Given this list of marker genes TDRD1, PCDHB7, USP18, HOXD4, TAF7L, KCNK9, CA10, HBZ, LHX9, NPY5R, OTOP3, ADGRL3, NPAS4 (NCBI Gene Id 266743), HOXB8, ALOX15, TFAP2D, HOXD10, CACNG2, OTP, TMEM174, TMEM59L, TBX5, HTR2C, HOXA3, HPSE2, HOXB5, ASIC2, RPH3A, VSNL1, TBX4 (NCBI Gene Id 9496), PHOX2B, PCDHA11, HOXA11, NR2E1, PCDHA4, ZMYND10, PYY, NALF1, CRLF1, FOXL1, PRDM13, CACNA1G (NCBI Gene Id 8913), HOXC10, ELOVL3, PCDHA10, EVX2, KCNS1, UNCX (UNC homeobox), WNT1, FGF12, SORCS3, HOXB6, HOXB3, PRDM8, HOXC6, ZNF536 (zinc finger protein 536), GRM8, PCDHB16, EREG, CALB1, HOXB1, MYCBP2, WNT10A, HOXA2, PAPPA, TFAP2B, USH1G, OSR1, NRN1, INSRR, NFIX, PCDHA13, HOXC9, KCNIP1 (potassium voltage-gated channel interacting protein 1), SLC6A4, LRRK2, PRRT1 (NCBI Gene Id 80863), SIX3, HOXB7, GFI1, DUOX2, DBX1, IGF2, LBX1, ARX, NTM, DUOXA2, ACTL6B, PCDHA2, NR2F2, CACNA1E, HBQ1, HOXC8, MPPED1, HOXB2, TEX12 (testis expressed 12), IL10RA, CDH11, AVP, PCDH11X, SLITRK3, ACHE, SLC25A31, here is a description of the gene set: from publication Mikkelsen TS, Hanna J, Zhang X, Ku M, Wernig M, Schorderet P, Bernstein BE, Jaenisch R, Lander ES, Meissner A (PMID 18509334) species: Mus musculus Genes with high-CpG-density promoters (HCP) bearing the tri-methylation mark at H3K27 (H3K27me3) in MCV8.1 (induced pluripotent cells, iPS). Human Gene Set: MIKKELSEN_IPS_WITH_HCP_H3K27ME3 Somatic cells can be reprogrammed to a pluripotent state through the ectopic expression of defined transcription factors. Understanding the mechanism and kinetics of this transformation may shed light on the nature of developmental potency and suggest strategies with improved efficiency or safety. Here we report an integrative genomic analysis of reprogramming of mouse fibroblasts and B lymphocytes. Lineage-committed cells show a complex response to the ectopic expression involving induction of genes downstream of individual reprogramming factors. Fully reprogrammed cells show gene expression and epigenetic states that are highly similar to embryonic stem cells. In contrast, stable partially reprogrammed cell lines show reactivation of a distinctive subset of stem-cell-related genes, incomplete repression of lineage-specifying transcription factors, and DNA hypermethylation at pluripotency-related loci. These observations suggest that some cells may become trapped in partially reprogrammed states owing to incomplete repression of transcription factors, and that DNA de-methylation is an inefficient step in the transition to pluripotency. We demonstrate that RNA inhibition of transcription factors can facilitate reprogramming, and that treatment with DNA methyltransferase inhibitors can improve the overall efficiency of the reprogramming process.